Given this list of marker genes Rgs4, Apc, Kcnk2, Ankrd26, Hdac2, Pten, Tbx5, Ptk2, Trp73, Tomm70a, Fxn, Zfp418, Men1, Rgs2, G6pdx, Slc6a4, Vgll4, Pi16, Cav3, Mapk11, Yy1, Wwc1, Rbm10, Cga, Wwc2, Cxadr, Dspp, Cited2, Tgfbr2, Pak1, Rbp4, Jarid2, Sav1, Tcf7l2, Gja1, Foxp1, G6pd2, Ctdp1, Stk4, Stk3, Mir1a-2, Ppara, Gsk3a, Nog (noggin), here is a description of the gene set: Any process that stops, prevents, or reduces the frequency, rate or extent of growth of an organ of an organism. Mouse Gene Set: GOBP_NEGATIVE_REGULATION_OF_ORGAN_GROWTH studied in species Mus musculus